The following is a description of a gene set: Human Gene Set: PID_ECADHERIN_KERATINOCYTE_PATHWAY from publication Schaefer CF, Anthony K, Krupa S, Buchoff J, Day M, Hannay T, Buetow KH (PMID 18832364) studied in species Homo sapiens E-cadherin signaling in keratinocytes, and this is the list of marker genes: PIK3CA, ZYX, CTNND1, RHOA, PIP5K1A, CTNNA1, CTNNB1, CASR, AKT1, RAC1, AJUBA, AKT2, VASP, JUP, SRC, EGFR, PIK3R1, FMN1, FYN, CDH1, PLCG1